Given this list of marker genes Rps27a, Chd1l, Rfc1, Pole2, Ddb1, Ercc4, Ubb, Cul4a, Ercc3, Ercc1, Gtf2h2, Rpa1, Cul4b, Pole, Ercc2, Pold1, Gtf2h4, Pold4, Pold2, Polk, Xpa, Pcna, Rfc3, here is a description of the gene set: studied in species Mus musculus electronically inferred by orthology from the curated human pathway This event has been computationally inferred from an event that has been demonstrated in another species.<p>The inference is based on the homology mapping from PANTHER. Briefly, reactions for which all involved PhysicalEntities (in input, output and catalyst) have a mapped orthologue/paralogue (for complexes at least 75% of components must have a mapping) are inferred to the other species. Reactome Pathway: Dual Incision in GG-NER part of: Global Genome Nucleotide Excision Repair (GG-NER)